The following is a description of a gene set: Mouse Gene Set: GOBP_BONE_GROWTH The increase in size or mass of a bone that contributes to the shaping of that bone. species: Mus musculus, and this is the list of marker genes: Stc1, Bnc2, Fosl2, Rarg, Kdr, Smpd3, Por, Msx2, Comp, Sox9, Enpp1, Thbs3, Col27a1, Ddr2, Dspp, Fbln5, Matn1, Rarb, Thbs1, Nppc, Lepr, Ift80, Npr2, Mmp13 (NCBI Gene Id 17386), Cst5, Tgfbr2, Ecm1, Carm1, Cer1, Rara, Atf2, Lep, Zmpste24, Ext1, Col9a1, Evc, Ostn, Poc1a